The following is a description of a gene set: Human Gene Set: MODULE_253 Intracellular transport (MT cytoskeleton and motors). species: Homo sapiens, and this is the list of marker genes: STMN1, MAP2, TUBB4B, DNM1, KIF2C, DCTN2, KIF3B, MAPRE1, MAP1B, TUBA4A, KIF5A, TUBB3, SNTB2, ARSB, CENPE, DYNLL1, KIF5C, KIF11, KIF14 (NCBI Gene Id 9928), KIF23, DYNC1LI2